The following is a description of a gene set: FCERI mediated NF-kB activation Human Gene Set: REACTOME_FCERI_MEDIATED_NF_KB_ACTIVATION studied in species Homo sapiens, and this is the list of marker genes: IGHV4-34, PDPK1, PSMA3, IGHV3-30, IGKV1-17, RASGRP2, LYN (NCBI Gene Id 4067), PSMD11, IGKV4-1, IGLV3-19, IGHV4-39, PSMD2, IGKV3-11, IGLV6-57, IGHV3-53, PSMD6, IGHV3-23, ADRM1, IGKV5-2, RASGRP1, IGKV1D-39, PSMA6, PSMB4, RELA, PSMC4, IGHV3-11, PSMA4, MS4A2, BTRC, PSMD8, IGHV3-48 (NCBI Gene Id 652106), PSMD7, UBE2D2, IGLV3-27, IGKV2D-40, MALT1, TAB2 (NCBI Gene Id 23118), PSMB7, IGHV4-59, IGKV1D-12, IGLV1-40, CUL1, IGHV3-13, IKBKB, IGHV3-7, IGKV1D-33, IGLV3-25, PSMD1, IGHV1-69, MAP3K7, UBE2N, PSMC5, IGLV2-23, IGLC3, IGLV2-8, PSMA1, IGLV1-51, PSMB5, IGKV1-5, TRAF6, PSMB2, TAB1, PSMB1, IGLV3-1, PSMD14, IGLV7-43 (NCBI Gene Id 28776), IGKV3D-20, IGKV2-28, IGKV2-30, CDC34, IGHV3-33, IGKV3-20, IGKV2D-30, PSMB3, BCL10, IGLV1-44, UBE2V1, IGKV1-33, NFKB1, TAB3, IGLC2, UBC, IGKV3-15, PSMB6, PSMC6, PSMD3, PSMD12, UBA52, PRKCQ, IGKV1-39, IGHE, RASGRP4 (NCBI Gene Id 115727), UBE2D1, IGKV2D-28, RPS27A, PSMA2, IGHV2-5, IKBKG, IGHV1-46, IGLV2-14, IGLV2-11, UBB, SEM1, IGLV1-47, IGHV2-70, IGLV3-21, IGKV1-16, PSMA5, NFKBIA, PSMC1, PSMA7, FBXW11, CHUK, IGHV1-2, PSMC3, FCER1G, FCER1A, IGKV1-12, IGKV1D-16, SKP1, PSMD13, CARD11, PSMC2